Given this list of marker genes TMED3, ITGA3, CHID1, MEIS2, SNX18, AFTPH, CADPS (calcium dependent secretion activator), KCNA6, ATP2B4, KLHDC1, RANBP6, AASDHPPT, TNN, USP31, MYL12A, HSD11B2, TM9SF1 (transmembrane 9 superfamily member 1), ALOX15, MYO9B, NUDT19, ARMC3, IQSEC2, ATXN7L3B, RALGDS, BTBD1, ADAM22, ARF3, TRPM1, MDGA1, RIPOR2, MAPK8, ARHGAP36, CAMK4, KIF5B, TPM2, PABIR1, COL4A3, NECTIN1, CUL4B, PCMT1, DTD1, STAG1, CARNS1, MDK, RNF148, PTPN23, THRB, DENND3, XPO1 (exportin 1), AKIRIN2, PPT1, here is a description of the gene set: Human Gene Set: MIR4253 Genes predicted to be targets of miRBase v22 microRNA hsa-miR-4253 in miRDB v6.0 with MirTarget v4 prediction scores > 80 (high confidence targets). species: Homo sapiens from publication Chen Y, Wang X (PMID 31504780)